Given this list of marker genes FCGR1BP, VAV2, FGR, MEGF10, ITGAM, TULP1, APOA2, PTPRC, CORO1C, PTK2, PIP5K1A, CNN2, ELMO2, PTPRJ, RAC1, ANXA1, APPL1, ANXA11, PIKFYVE, RARA, ALOX15, SLC48A1, LYAR, CAMK1D, HAVCR1 (hepatitis A virus cellular receptor 1), PLCG2, TYROBP, PIP5K1C, CCR2 (NCBI Gene Id 90262), SNX3, PLPP4, ITGB1, UNC13D, BIN2 (NCBI Gene Id 51722), LEPR (leptin receptor), CD47, TIMD4, RAB7A, GULP1, MSR1, TREM2, DOCK2, RAP1GAP, VPS33B, CEACAM4, ABCA7, ARHGAP12, CORO1A, MYO18A, IL2RB, SLC11A1, SYT7, PLD2, YES1, FCGR2C, SCARB1, PLSCR1, XKR4, BECN1, ELMO3, MARCO, ADORA2A (adenosine A2a receptor), FCN2, ATG3, SPG11, BCR, BTK, C4BPA, ANO6, XKR6, RAB20, FCER2, SFTPD, MERTK, ABL1, FCGR2B, LRP1, APPL2, PIK3CA, XKR8, C4B, RUBCN, DNM2, TGM2, FCGR1A, PEAR1, SOD1 (superoxide dismutase 1), LIMK1, C3, CCL2, RACK1, MBL2, CDC42SE2, AHSG, CD36, CALR, DOCK1, RAB27A, FPR2, PLA2G5, CLN3, SPHK1, PECAM1, TLR2, FCGR2A, PRTN3, PTX3, PRKCD, LETMD1, FCN1, LEP, LYST, CSK, CYBA, MYO7A, ADIPOQ, PLD4, AIF1 (NCBI Gene Id 9471), TAFA4, ICAM5, MST1R, CD302, MYD88, SIRPG, SPACA3, CRYBA1, ITGAV, ITGAL, ELMO1, CRP, TUB, COLEC10, TLR4, PRKCG, TREX1, COLEC12, SYK (spleen associated tyrosine kinase), PRKCE, HCK, RAB7B, AGER, ADORA1, CLCN2, TICAM2, NR1H3 (nuclear receptor subfamily 1 group H member 3), IRF8, CD300A, CD14, RAB39A, ELANE, HMGB1, SIRPB1 (signal regulatory protein beta 1), RAP1A, ARAP1, RAB31, AZU1, VAV1, NCF2, MYH9, P2RY6, ITGB2, MIR183, VIPAS39, SYT11, GAS6, RAB34, CLEC7A, AXL, GSN, CFP, MFGE8, STAT3, IFNG, NCF4, XKR7, ANXA3, ITGA2 (NCBI Gene Id 3673), CLCN3, CDC42SE1, F2RL1, SRC, SH3BP1, LYN (NCBI Gene Id 4067), ADGRB1, ARHGAP25, SRPX, RAB5A, ATG5, PIP4P2, IL15, PRKACA, TGFB1, VAV3, NCKAP1L, ITGB3, ICAM3, SLAMF1, GATA2, MIR181B1, SFTPA1, TUSC2, C4A, TMEM175, C2, IL2RG, THBS1, CD300LF, NOS2, P2RX7, FCER1G, MYO1G, MIR17, C1orf43, CD93, LBP, TYRO3, APOA1, ABCA1 (NCBI Gene Id 8371), COLEC11, VAMP7, IL15RA, MIR20A, JMJD6, RAB11FIP2, RAB14, SPON2, PLA2G6, FYN, C4BPB, CEBPE, ARL8B (NCBI Gene Id 55207), BLTP1, MESD, TM9SF4, DYSF, FCN3, PYCARD, PAK1, STAP1, LMAN2, SIRPA, LDLR, EIF2AK1, CDC42, here is a description of the gene set: studied in species Homo sapiens Human Gene Set: GOBP_PHAGOCYTOSIS A vesicle-mediated transport process that results in the engulfment of external particulate material by phagocytes and their delivery to the lysosome. The particles are initially contained within phagocytic vacuoles (phagosomes), which then fuse with primary lysosomes to effect digestion of the particles.